The following is a description of a gene set: Mouse Gene Set: GOBP_CHROMOSOME_ORGANIZATION_INVOLVED_IN_MEIOTIC_CELL_CYCLE studied in species Mus musculus A process of chromosome organization that is involved in a meiotic cell cycle., and this is the list of marker genes: Syde1, Meioc, Morc2b, Fancd2, Tex12, Mcmdc2, Brip1, Prdm9, Bag6, Tex15, Ncapd3, Ankrd31, Mael, Mre11a, Ncaph, Sycp3, Terf1, Syce2, Tex19.1 (testis expressed gene 19.1), Dmc1, Msh4, Bend2, Rec8, Smc2, Rnf212b (NCBI Gene Id 102632837), Psmc3ip, Ube2b, Rnf212, Cep63, Ago4 (NCBI Gene Id 76850), Rad21l, Ccnb1ip1, Mei4, Sun1, Rad51, Ehmt2, Meiob, Stag3, Spo11, Kash5, Msh5, Shoc1, Ccne2, Zcwpw1, Smc4, Terb1, Mlh1, Mlh3, Rad50, Mnd1, Iho1, Ncapd2 (non-SMC condensin I complex, subunit D2), Syce1, Tex11, Ccne1, Spata22, Atm, Sirt7, Syce1l, Syce3, Ndc1, Haspin, Mei1, Hormad1, Spdya (NCBI Gene Id 75331), 4930447C04Rik, Majin, Cpeb1, Atrx, Sycp1, 1700028K03Rik, Ncaph2, Terb2, Trip13 (thyroid hormone receptor interactor 13)